Given this list of marker genes TIMP3, LIX1L, BCHE, GAGE12F, DUSP1, NEK2, TACR1, VAMP8, SGK1, CGA, ZGLP1, MALAT1, TNFRSF11B, MAGEA5P (MAGE family member A5, pseudogene), ADGRF2P, ABI3BP, SPP1, WNT5A, CCL21, DAPK1, VEGFC, TMEM98, RGCC, EMP3, H2BC21 (NCBI Gene Id 8349), AGT, ITM2A, PRAME, GPC3, MAGEA6, ELAVL2, FABP3, EDNRB, TCEAL9, GYG2, here is a description of the gene set: from publication Hernández-Vargas H, Palacios J, Moreno-Bueno G (PMID 17099726) studied in species Homo sapiens Genes up-regulated in MCF7 cells (breast cancer, normal TP53) undergoing mitotic arrest and apoptosis after treatment with 100 nM docetaxel. Human Gene Set: HERNANDEZ_MITOTIC_ARREST_BY_DOCETAXEL_1_UP Among microtubule-targeting agents, docetaxel has received recent interest owing to its good therapeutic index. Clinical trials have underlined its potential for the treatment of advanced breast cancer, although little is known about its molecular mode of action in this context. We characterized the molecular changes induced by docetaxel in two well-known human breast carcinoma cell lines. Two mechanisms of action according to drug concentration were suggested by a biphasic sensitivity curve, and were further validated by cell morphology, cell cycle and cell death changes. Two to four nanomolar docetaxel induced aberrant mitosis followed by late necrosis, and 100 nM docetaxel induced mitotic arrest followed by apoptosis. Passing through mitosis phase was a requirement for hypodiploidy to occur, as shown by functional studies in synchronized cells and by combining docetaxel with the proteasome inhibitor MG132. Transcriptional profiling showed differences according to cell line and docetaxel concentration, with cell cycle, cell death and structural genes commonly regulated in both cell lines. Although p53 targets were mainly induced with low concentration of drug in MCF7 cells, its relevance in the dual mechanism of docetaxel cytotoxicity was ruled out by using an isogenic shp53 cell line. Many of the genes shown in this study may contribute to the dual mechanism by which docetaxel inhibits the growth of breast cancer cells at different concentrations. These findings provide a basis for rationally enhancing docetaxel therapy, considering lower concentrations, and better drug combinations.